The following is a description of a gene set: part of: p75NTR signals via NF-kB NF-kB activation involves recruitment at the cell membrane of several proteins such as RIP2, MYD88, IRAK1, TRAF6, p62 and atypical PKC by the NGF:p75NTR complex. species: Homo sapiens Reactome Pathway: p75NTR recruits signalling complexes, and this is the list of marker genes: NGF, UBA52 (NCBI Gene Id 7311), RIPK2, IRAK1, UBC, RPS27A, SQSTM1, PRKCI, MYD88, TRAF6, NGFR, UBB, IKBKB (NCBI Gene Id 3551)